The following is a description of a gene set: Mouse Gene Set: RUAN_RESPONSE_TO_TNF_TROGLITAZONE_DN from publication Ruan H, Pownall HJ, Lodish HF (PMID 12732648) species: Mus musculus Adipocyte abundant genes down-regulated in 3T3-L1 cells (fibroblasts induced to differentiate to adipocytes) in response to troglitazone and TNF. Troglitazone (TGZ), a member of the thiazolidinedione class of anti-diabetic compounds and a peroxisome proliferator activator receptor-gamma (PPAR-gamma) agonist, restores systemic insulin sensitivity and improves the full insulin resistance syndrome in vivo. The mechanisms underlying its in vivo function are not understood. Here we investigated the potential functional interaction between PPAR-gamma and NF-kappaB in adipocytes. We show that TGZ selectively blocked tumor necrosis factor-alpha-induced and NF-kappaB-dependent repression of multiple adipocyte-specific genes and induction of growth phase and other genes. This occurs without interfering with NF-kappaB expression, activation, nuclear translocation, or DNA binding and without suppressing NF-kappaB-dependent survival signals. Notably, the expressions of some tumor necrosis factor-alpha-induced genes in adipocytes were unaffected by PPAR-gamma activation. In reporter gene assays in HeLa cells, ectopic expression of PPAR-gamma abolished induction of a NF-kappaB-responsive reporter gene by the p65 subunit (RelA) of NF-kappaB, and the inhibition was further enhanced in the presence of TGZ. Conversely, overexpression of p65 inhibited induction of a PPAR-gamma-responsive reporter gene by activated PPAR-gamma in a dose-dependent manner. The inhibitory effect was independent of the presence of NF-kappaB-binding sites in the promoter region. Other NF-kappaB family members, p50 and c-Rel as well as the S276A mutant of p65, blocked PPAR-gamma-mediated gene transcription less effectively. Thus, p65 antagonizes the transcriptional regulatory activity of PPAR-gamma in adipocytes, and PPAR-gamma activation can at least partially override the inhibitory effects of p65 on the expression of key adipocyte genes. Our data suggest that inhibition of NF-kappaB activity is a mechanism by which PPAR-gamma agonists improve insulin sensitivity in vivo and that adipocyte NF-kappaB is a potential therapeutic target for obesity-linked type 2 diabetes., and this is the list of marker genes: Fxyd1, Alad, Cfd, Adrb3, Retn, Idh1, Rnf11, Cbx4, Idh3g, Hipk2, Pparg, Orm1, Dhrs3, Pfkfb1, Tst, Ap3s1, Apoc4, Hk2, Cdkn2c (NCBI Gene Id 97133), Pxmp2, Aoc3, Pcx, Rgs2, Selenbp1, Rasd1, Adipoq, Irx3, Tpp2, Pla2g6, Cib2, Hsd17b4, Fasn, Aqp7, Gpam, Nrip1, Mmut, Abcd2, Lpl, Slc2a4